Given this list of marker genes EPS15L1, SLC17A7, NLGN1 (neuroligin 1), SNCB, AP3S2, CALM1, BIN1, ACTB, DNM2, PIK3C3, AP1G1, AP2B1, SYNJ2, ATP8A1, DNAJC6, ROCK1, BTBD9, AP3B2, MX2, AP2S1, PRKN, PARK7 (NCBI Gene Id 113880), ITSN1, SNX9, CAPN2, OPHN1, ARF6, SLC2A4, AP2A1, SCRIB, VAMP2, AP2M1, DNM3, AP3M2, RAC1, NECAP1, CLTB, PACSIN1, PPP3CB, BLTP1, SGIP1, CALM2 (calmodulin 2), CALM3, NLGN3, TOR1A, CDK5, CLTA, SYNJ1, AMPH, MYLK, AP3D1, FCHO2, DNM1, STON1, GAK, AP2A2, PIP5K1C, AAK1, TBC1D24, LRRK2, CTBP1, STON2, VAMP4, BTBD8, DGKQ, STX1A, SH3GL2, MX1, ABCA13, SNCG, ACTG1, PPP3CC, CANX, SYT11, ARPC3, RAB27B, AP3S1, SNCA, SYT7, ITSN2, here is a description of the gene set: A vesicle-mediated transport process in which the presynapse take up external materials or membrane constituents by the invagination of a small region of the plasma membrane to form a new membrane-bounded vesicle. studied in species Homo sapiens Human Gene Set: GOBP_PRESYNAPTIC_ENDOCYTOSIS